The following is a description of a gene set: species: Mus musculus Binding to a tumor necrosis factor receptor. Mouse Gene Set: GOMF_TUMOR_NECROSIS_FACTOR_RECEPTOR_BINDING, and this is the list of marker genes: Siva1, Tnfsf13b, Tnfsf14, Traf2, Traf1, Tnf, Tnfsf4, Fadd (NCBI Gene Id 14082), Traf5, Stat1, Tnfsf11, Lta, Cd40lg, Tnfsf13, Fasl, Tnfsf8 (NCBI Gene Id 21949), Tnfsf9, Eda, Tnfsf10, Ltb, Trim37, Tnfsf12, Erap1, Traf6, Babam2, Casp8, Nucb2, Traf3 (NCBI Gene Id 22031), Tradd, Cd70, Tnfsf18, Tnfsf15, Traf4